The following is a description of a gene set: Enables the transmembrane transfer of a solute by a channel that opens in response to a specific ion stimulus. studied in species Mus musculus Mouse Gene Set: GOMF_MONOATOMIC_ION_GATED_CHANNEL_ACTIVITY, and this is the list of marker genes: Kcnmb3, Kcnn2, Tmem63a, Ano1, Kcnk18, Ano10, Tmem38a, Kcnmb1, Kcnmb2, Kcnt2, Asic2, Trpc3, Asic1, Trpm5, Kcnn3, Pkd1l3, Kcnu1, Tmem63b, Catsper2, Catsper4, Pkd2l1, Trpm4, Kcnma1 (potassium large conductance calcium-activated channel, subfamily M, alpha member 1), Ano6, Kcnn4, Kcnmb4, Kcnt1 (NCBI Gene Id 77377), Calhm1, Kcnn1, Catsper1 (cation channel, sperm associated 1), Tmem63c